Given this list of marker genes Septin12 (septin 12), Septin7, Septin2, Septin10, Ddx6, Adgb, Septin4, Slc26a8, Septin6, here is a description of the gene set: Mouse Gene Set: GOCC_SPERM_ANNULUS species: Mus musculus The ring-like, filamentous structure located at the distal end of the midpiece of the sperm flagellum; the annulus is thought to form a diffusion barrier between the midpiece and the principal piece and serve as a stabilizing structure for tail rigidity.